The following is a description of a gene set: species: Homo sapiens Human Gene Set: GSE17721_PAM3CSK4_VS_CPG_2H_BMDC_UP mouse primary BMDCs were stimulated with tlr ligands and gene expression changes were profiled on Affymetrix arrays Genes up-regulated in comparison of dendritic cells (DC) stimulated with Pam3Csk4 (TLR1/2 agonist) at 2 h versus DC cells stimulated with CpG DNA (TLR9 agonist) at 2 h. from publication Amit I, Garber M, Chevrier N, Leite AP, Donner Y, Eisenhaure T, Guttman M, Grenier JK, Li W, Zuk O, Schubert LA, Birditt B, Shay T, Goren A, Zhang X, Smith Z, Deering R, McDonald RC, Cabili M, Bernstein BE, Rinn JL, Meissner A, Root DE, Hacohen N, Regev A (PMID 19729616), and this is the list of marker genes: DCLRE1A, TMEM45A, RTL8C, PSMB4, SLC22A13, PUS1, AQP2, KBTBD4, LRRC14, TRIB2, IL21R, ISL2, TOPBP1, GOLGA2, CRYZ, POF1B, MPHOSPH9, SHC1, APBB3, SMG5, PLEKHF1, CCNA1, OPN1SW, PARP4 (poly(ADP-ribose) polymerase family member 4), ZNF277, CNNM2, APRT, WNT9A, IL21, HSP90AA1, WNT9B, ZNF239, WNT4, SMYD2, ARL4A, PTGDR2 (NCBI Gene Id 9484), FCER1G, LAMP5, IL17D, KY, THOC2, TTN, PLXNA3, MARCHF2, HDHD3, HSD17B2, ZFP64, VSIG4, SLC25A35, SESN1, LINGO1, MED14, COL4A6, EBF3, FOXA1, PRMT5 (NCBI Gene Id 415048), GNE, GUCA2A, SRCAP, ABHD18, TSPAN12, SPIC, PDZRN3, ASPRV1, RGS6, IL17RE, ERN2, NF2, RASAL2, MRPL20, HMCES, SMARCC1, ARMC12, C1orf43, CAPRIN2, EN1, CDC42EP4 (CDC42 effector protein 4), HAUS7, FAM131B, POLR3E, MMAA, TNFRSF12A, EFNA4, HOXA7, ZAP70, CEP290, EFNA2, ZNF124, VAX2, MRPL9, PRRT1, SAA2, ZFP1, DNAH5, LPIN3, ATG5, GSPT2, ZNRD2, TPBG, CDKN2D, SNCA, PLAAT1, NOL6, PRSS22, CRCP, CRYAB, IL6R, CD40LG, AGTR2, MAP1B, ALDH1A3, BHMT, CHD8, DOK3, OMA1, DOC2A, IGLL1, POU3F3, KCTD4, IFNAR2, DCAF5, GLB1L, KCTD2, DNAJC3, SRCIN1, PBXIP1, HTR7, BCAM, RPS10, PGR, GLIS1, FAM162A, PRDX1, FGF17, RPAP3, ZNF821, NIF3L1, RALGPS2, PYY, PDIA6, SLC1A2, TPCN1 (NCBI Gene Id 56236), ITGBL1, MYF5, ANXA4, PDX1, ICAM5, ARPP21, CORO1C, GIMAP7 (NCBI Gene Id 168537), NUDT16, ADAMDEC1, RFXAP, LMNB2, SLC38A4, NXN, EFEMP1, AKR1B15, GRIK3, ZBTB48, RPS3, JUND, GTF2I, SNRPB, SNTG2, NIPSNAP1, AFTPH, ZBTB1, TCTE1, MKKS, KDM5A, OCA2, ACAD9, IKZF4, NUP155, CLGN, KCND2, IFT88, RRH, COL12A1, N4BP3, LRRK1, FBXO21, SLC44A1, NECTIN4, KLF10, CD44, TCF21, KLHL13, SCN7A, DNASE1L3, UBE3C, METTL22, CALN1, SLC25A44, GRIN3B, UTS2, WDR45B, CHST14